Given this list of marker genes RPGRIP1L, CEP83, MYO5B, DCDC2, WDR35, PYGL, ADK, PHKG2, PHKA2, CC2D2A, ATP7B, UNC45A, ABCB4, ABCD3, SLC25A13, ARG1, here is a description of the gene set: Fibroblast proliferation and fiber expansion from the portal areas to the lobule. Portal fibrosis Human Gene Set: HP_PORTAL_FIBROSIS species: Homo sapiens